The following is a description of a gene set: Embryonic stem cell pluripotency pathways Human Gene Set: WP_EMBRYONIC_STEM_CELL_PLURIPOTENCY_PATHWAYS species: Homo sapiens, and this is the list of marker genes: DVL1, WNT9B, WNT4, FGF6, MAPK12, FGF8, FZD1, FGF1, FGF4, WNT10B, GAB1, MAPK7, FZD6, EGF, FGF10, FOS, MDM2, ACVR2B, FGFR2, LRP5, MAPK4, DVL3, JAK1, SOS1, RAF1, IL6ST, SMAD4, WNT5A, SMAD9, FZD2, LIF, MAP2K3, BMPR2, JUN, FGF21 (fibroblast growth factor 21), GRB2, MAP2K6 (mitogen-activated protein kinase kinase 6), FGF23, PTEN, FGFR4, GSK3B, WNT10A, FGF12, PIK3R2, SELENOP, FZD7, PDGFA, AKT1, WNT16, WNT5B, FZD3, STAT3, FGF14, WNT1, WNT7A, WNT2B, FZD4, PIK3CD, ARAF, ACVR1, ACTR2 (actin related protein 2), CTNNB1, BMP4, FGFR1, FGFR3, MAP2K2, PTPN11, BMPR1B, LIFR, HRAS, FGF9, HNF1A, FGF20, EGFR, AXIN1, FGF5, WNT6, FGF16, MTOR, SMAD7, ELK1, WNT3A, SMAD6, FGF3, WNT11, FZD9, SMAD1, PDGFRA, WNT3, FGF2, WNT2, MAPK6, FGF13, APC, FZD8, AKT2, SMAD5, AKT3, FGF18, LRP6, DVL2, WNT7B, PDGFRB, MAP2K5, BRAF, BMPR1A, FGF11, FGF7, NOG, FGF17, FGF22, MAP2K1, PDGFB, FZD5, MAPK1, FGF19, ERAS